Given this list of marker genes BCLAF3, E2F1, CSNK2A1, ANKRD55, ACAD11, XPO1, here is a description of the gene set: Human Gene Set: MIR4444 Genes predicted to be targets of miRBase v22 microRNA hsa-miR-4444 in miRDB v6.0 with MirTarget v4 prediction scores > 80 (high confidence targets). studied in species Homo sapiens from publication Chen Y, Wang X (PMID 31504780)